Given this list of marker genes SLAMF1, BCL2L2, G0S2, CD58, ISG20, EIF2AK2, HIVEP2, UBE2Z, IFI27, GRINA (NCBI Gene Id 2907), CD83, HLA-F, PTGIR, PLAGL1, HLA-E, DUSP2, H2BC6, SPG11, MSC, VRK2, NFIL3, H1-10, OAS2, REL, BTN3A2, H2AC25, RASGRP1, ZC3H12A, IRF9, SAMD9, OASL, IFI35, DYNLT1, TNFAIP3, IRF4, LMBR1L, XPO6, CASP7, IFI44, PPP3CC, RTP4, USP18, TLK2, TGIF1, HEATR6, CCL20, SHFL, IL2RA, GMPR, LY75, CFP, IFI44L, PPP1R15A, MAP3K13, IFIT2, B3GALT4, IMPA1, CFB, SAMSN1, EZH1, NFKB2, KYNU, TAP1, HLA-B, JPT1 (Jupiter microtubule associated homolog 1), PSME2, CRLF3, LGALS3BP, WDR48, BIRC3 (baculoviral IAP repeat containing 3), PDE4B, BTG1, MT2A, SEC61B, IRF7, EBI3, OAS3, NINJ1, COPS2, EOLA1, H4C8 (NCBI Gene Id 8365), H2BC5, TRIP4, IFIT5 (interferon induced protein with tetratricopeptide repeats 5), IFIT3, RHBDF2, IFITM3, DDX60, ADAR, IL12B, TMEM39A, IFITM1, TNIP1, SOD2, XAF1, DDA1, GYS1, PSMB8, PIM2, PAQR3, PHF11, STK4, CLDND1, MOB1A, MTSS1, MX2, CXCR4, TBC1D9, APOBEC3A, DNAJA1, CHMP5, IFIT1, TYMP, GTPBP1, TASOR2, TBC1D8, P2RX4, CREB3, LMNB1, GBP1, BTN3A3, CCR7, HERC6, PMAIP1, DUSP5, BTG3, PSMB9, RIPK2, CDCA4, ABRAXAS2, PSMB10, H2BC12L, ETV6, TXN, SQSTM1, DUSP1, TNFRSF9, ICAM1, MVP, MARCKSL1, SLAMF7, CALM3, HLA-G, RIGI, HERC5, RAB8B, IDO1, GPX4, CNP, WARS1, CCL5, IL15RA, SCO2, LAMP3, H2BC21, IFI6, TMEM131L, HSPA1A, STAT1, GCH1, H2BC9, SPRED2 (sprouty related EVH1 domain containing 2), RAB9A, HLA-A, APOL1, IER5, PRKAR2B, BST2, RSAD2, VANGL1, TRAF1, NMI, ZDHHC18, TEX30, CASP3, DHX58, TNFAIP8, LAP3, PTGER4, NR4A3, UBE2L6, NFKB1, ISG15, TNFSF4, HLA-J, TNFAIP6, NFE2L1, SP110, TBC1D13 (NCBI Gene Id 54662), CSRP2, ZER1, TNFSF10, NAPA, NCF1C, IFIH1, TPD52, RUBCN, IFITM2, BTN3A1, H2AC6, here is a description of the gene set: Human Gene Set: GSE22886_CTRL_VS_LPS_24H_DC_DN Genes down-regulated in comparison of unstimulated dendritic cells (DC) versus 1 day DC stimulated with LPS (TLR4 agonist). species: Homo sapiens Immune cell-specific expression is one indication of the importance of a gene's role in the immune response. In order to identify such patterns, we set out to broadly profile gene expression in a variety of immune cells. from publication Abbas AR, Baldwin D, Ma Y, Ouyang W, Gurney A, Martin F, Fong S, van Lookeren Campagne M, Godowski P, Williams PM, Chan AC, Clark HF (PMID 15789058)